Given this list of marker genes NEURL4, PKHD1, MDM2, RITA1, TGIF2, DYNLRB1 (dynein light chain roadblock-type 1), MAP4, FANK1, CDK1, MAPK15, CEP78, DCDC2B, MASTL (microtubule associated serine/threonine kinase like), CEP85, PKD2, NAA40 (NCBI Gene Id 79829), CEP57L1, BUD31, PRKACA, CAMSAP3, CCDC170, KMT5B, ATP6V1D, LHCGR, STIL, PLK2, ATF4, APC (NCBI Gene Id 324), USP20 (NCBI Gene Id 10868), MFAP1, POGZ, GLG1 (golgi glycoprotein 1), RAD51, LRRCC1, KNCN, AGBL4, ACTR1A, FRY, CEP192, IFT74, RAB8A, IST1, CLTC, MAP10, NPHP4, FLCN, RELB, UVRAG, IFT57, NUBP2, KATNBL1, TEDC2, SPAG8, DCAF12, CAMK2B, XRCC2, DEUP1, UBXN2B, SLAIN2, ODAD3, CCDC102B, SPATC1, USP33, KMT2E, LZTS2, HSPA1A, JTB, HMBOX1, WDR11, DYSF, ITSN2, DCTN5, ADCY9, B9D2, CNTRL, CDK5RAP2, TUBE1 (tubulin epsilon 1), SLMAP, TRAF5 (NCBI Gene Id 7188), BRSK1, TM9SF2, FLOT1, GSK3B, FAM110B, SFI1, UNC5CL, TPGS2, TNKS, PIK3R5, KIF7, CCDC112, RAB34, CFAP157, NDN, BBS7, TAP1 (transporter 1, ATP binding cassette subfamily B member), CCNE2, WHRN, KIF3B, CEP152, RAN, MYOF, CRMP1, FANCE, RAB11A, TBC1D30, PRKCQ, CEP162, CDKL2, PSMC4, CLASP1, CEP350, BCCIP, NLRC3, CFAP184, FFAR4, LATS1, CTNNBL1, HAUS2, LRWD1, H2AX, TTC23L, CCP110, CSAG1, PARP3, CEP104, UBXN6, PAK1, MAP7D1, BUB1B, SPMIP4 (sperm microtubule inner protein 4), FBXL7, TUBGCP2, RAD18, TSSK2, TUBG2, FNIP2, RAC1, CD2AP, TSGA10, DYRK3, MTUS1, DYNLRB2, INTU, DCLRE1B, KIAA0753 (NCBI Gene Id 9851), CALML3, PLEKHG6, TTC39A, RAB11FIP4, SNAP29, CEP164, CCDC8, PPP4R2, PDZD7, NCKAP5L, CCNF, HAUS6, RAB6C, MISP, GLI1, CC2D1A, ATM, CETN1, SLC18A2, SMAD3, RLBP1, CADPS2, EPB41L3, CREB1, CEP120, CEP63, CCDC68, ANKS1B, POLA2, ROCK1, CLASP2, BLOC1S2, LRRC45, ODF2, STOX1, FCMR, PDZD2, CCT5, CFAP126, PTPN20, PRKAR2A, PSEN1, RPGRIP1L, TAPT1, MLF1 (NCBI Gene Id 4291), CDC27, CYLD, AGBL2, CFAP100, ASPM, NEK1, RPP25, DCDC2, FRMD8, TEK, HSPA1B, PRKAA2, TTLL6, NPM1, CCNB1, APOBR, BNIP2, ZBED1, SMAD4 (SMAD family member 4), DZANK1, LCK, TULP3, SSNA1, POC5, SASS6, DENND1C, PPP4R3A, MPP1, JADE1 (NCBI Gene Id 79960), ZBED6, NIT2, CLIC4, PRKAA1, PTPN23, PLA2G3, CPLANE2 (ciliogenesis and planar polarity effector complex subunit 2), TOPBP1, ARHGEF10, CKAP2L, TTLL9, KAT2A, DYNC1LI2, PRKAR1A, C2CD3, MICALL1, CFAP206, KLHL4, IFT20, BBS1, ACLY, TRIM32, ORC2, BICDL1, RP2, GAS2L2, CEP72, ZNF330, DZIP1L, IFT43, CAPRIN2, NDE1, MAP7D2, RPS7, CENPF, ATF5, PCNT, CEP41, PIK3R4, RGS14, FAM110C, CNTLN, TSKS, ADRB2, WDR62, CEP20, CHODL, ALDOB, FAM161A, ZFYVE26, CHEK1, GLI2, CHD3, MECP2, DIAPH3, RASSF7, AAAS, GRB2, TBATA, SNCG, TTC12, RTRAF, ENTR1, ADH1B, LRIF1, NAA11, CCDC18, PXK, CCDC81, OFD1, WDR35, KIAA1217, POC1A, EFHC1, IFT22, VIM, FTCD, TRAT1, TTC28, HOOK3, DYNC2LI1, SAC3D1, KIFAP3, CCDC14, TCP1, ZMYND10, IFT172, NDRG1 (NCBI Gene Id 7998), EYS, CCDC57, AKT3, KAT2B, PPP4C (NCBI Gene Id 5531), IFT46, HSF1, TTLL12, CEP57, CEP128, BOD1L2, CCDC61, LRRK2, CEP76, HAUS3, DAPK3, KEAP1, MAPRE2, CBY1, RTTN, KIFC3, KIF3A, CDC14A, SLC8A3, NME3, KIF2B, RABL6, PATJ, CCDC22, NEDD1, EVC, CEP290, PDE4DIP, CCDC92, IRAG2 (inositol 1,4,5-triphosphate receptor associated 2), TTLL4, CFAP20, AKT1, SMAD7, GNAI1, MID1, TRIP4 (thyroid hormone receptor interactor 4), CFAP298, ARMC9, HNMT, SGO1, SDCCAG8, GEN1, STK3, NSFL1C, EEF1AKMT3, DIS3L, CCT4, CHRM2, NINL, BRCA2, VPS4B, MAD1L1, ANKRD26, ARHGEF7, CCNO, TBC1D31, TTLL5, MZT1, MYO18A, VCP, MME, SAXO1, CDK2, DDHD2, TP53, TRIM43, USO1, AGTPBP1, HORMAD2, PIN1, TSG101, SKI, SNTB2, CHMP1A, RIC8B, UBN1, PPP4R3B, ECPAS, CIB1, ARFGEF2, MNS1, NCAPD2, RBM39, MARK4, AKAP11, NDC80, HEPACAM2, E2F1, RAB6A, STK11, MCRS1, KATNAL2, ALS2, NUMA1, PCGF5, MARCHF7, CCNE1, CEP89, DCTN6, RPGR, AUNIP, SLC16A1, KIF5B, SPAST (NCBI Gene Id 6683, spastin), TRIM69 (tripartite motif containing 69), CDC42, RAB11FIP5 (RAB11 family interacting protein 5), CHD4, PODXL, CCDC146, CCDC77, STEEP1, RNF19A, WRAP73, NIN, RAB3IP, EZR, NCBP2, CIBAR1, KATNB1, MICAL1, EML4, IL4R, SKA1, MCPH1, RRP7A, DDX11, CEP131, PSEN2, CALM3, FIGN, FAM234B, CROCC, PRKD3, DYNLT4, HAP1, ATXN10, SCYL1, IL1RN, CLIP1, MKS1, CENPJ, PAX2, USP9X, TAF1D, DLG5, CCSAP, CTSC, MPHOSPH9, DYNC1H1, CDK5RAP3, EFHC2, TSEN2, OLA1 (Obg like ATPase 1), WRN (WRN RecQ like helicase), CDC25B, IQCB1, KIF11, CCDC66, CCDC28B (NCBI Gene Id 79140), FBXW11, NEIL1, TEKT2, SMO, TTBK2, SIRT2, KIF18A, RUVBL1, DNAI1, KATNIP, CDKL5, ARL2BP, YPEL5, CEP95, AURKC, PBOV1, WASHC1, ARL3, CEP126, USH1G, HNRNPU, BOD1, FBXW8, USP50, ACAA2, PPP2R5A, CSNK1A1, DYRK1A, CDC45 (cell division cycle 45), AJUBA, TTLL1, TRAPPC14, TTLL11 (NCBI Gene Id 401550), SPPL2B, RRM1, TCEA2, HOOK2, PSMA1, MAK, ARHGAP35, CUL7, TXNDC9, AXDND1, CCNB2, CEP19, KIF20B, MAPK1, FAM110A, WDR90, CCT8, PJA2, ANKRD45, TBC1D7, PRKACB (NCBI Gene Id 5567), IQSEC1, MAPK3, MPLKIP, PRKCZ, FBF1, TMEM67, PPP4R4, EYA3, DYNLL2, ATP6V0D1, CCDC116, MLLT11, SPACA9, CROCC2, VPS37A, PDCD6IP, ADH1A, S100B, CCDC13, IFT52, SKA3, OCRL, MAMLD1, UBR4, BAG3, PLK1, DPF2, KIF2A, CCND3, TENT5C, NUDT21, RABEP2, EXOC4, ZFYVE19 (zinc finger FYVE-type containing 19), CCDC78, DRD4, GPR174, DHX9, PTK2, PPP1R35, RPAP3, TBCCD1, ZNF322, DYNLT2B (dynein light chain Tctex-type 2B), EMD, NEK7, ABCC3, FAM184A, CCHCR1, POC1B, UTRN, SPOUT1, HTT, ARL13B, NFS1 (NFS1 cysteine desulfurase), TCHP (trichoplein keratin filament binding), CEP170, RILPL2, DBH, LRRC49, DIAPH1, MAP3K11, SCLT1 (sodium channel and clathrin linker 1), RGCC, BRSK2, BCL2L1, RABL2B, CCNJL, KIF13A, KIF17, DYNC2I2, TBCD, YTHDF2, CCDC65, PAFAH1B1, STX1B, CFAP410, IVL, PSMB4, CETN3, NUBP1, CIP2A, CCNJ, ILRUN, NUP85, KIF15, SNX10, WASH3P, ECT2, ATP2B4, CDH23, DAW1, SPATA7, MAP1S, AXIN2, CENATAC, NR3C1, CCDC88C, BIRC5, PRKAR2B, MAPKAPK2, AHI1, CEP295NL, PSKH1, CKAP5, TTLL13, RAB11FIP3, PSMB5 (NCBI Gene Id 5693), BICD1, GNAI2, CCND1, CFAP263, STING1, ACTR1B, CFAP70, CCDC62, CEP135 (centrosomal protein 135), SPECC1L (NCBI Gene Id 8221), C2CD5, RASSF1, HARBI1, NFE2L2 (NCBI Gene Id 4780), TNKS2, ABRAXAS2, CRACR2A, IFT88, CENPU, LUZP1, KIAA0586, TTC19, CCNA2, TTC8, BBS4, DYNC1LI1, TPPP, NEK2, CLIC5, CAMSAP2 (calmodulin regulated spectrin associated protein family member 2), SMG6, CEP112, PCM1, HDAC6, ADH1C, SFR1, CTAG2, AURKB, SEMA4D, CNTROB, PCNA, LIMK2 (NCBI Gene Id 3985), MVB12A, CCND2, CDKN1B, TUBGCP5, DCTN1, KLHL12, CDC42BPG, RAP1GAP2, PLK5, SEPTIN1, MIB1, DDX3X, TMEM201, AKNA, CIBAR2, TTLL2, USH2A, GPSM2, IFT27, ROCK2 (Rho associated coiled-coil containing protein kinase 2), CCDC124, PLAG1, PQBP1, TRAF3IP1, CAPG, NLRC5, MZT2A, HAUS1, ENKD1, IFT80, SMAD6, TOP2A, CEP83, KNSTRN, ALMS1, SPATC1L, DCDC2C, PPP1CC, TUBG1, SLF1, B9D1, NDEL1, PPP1R12A, TTLL7, MMS19, BBS2, CDK10, CCDC50, SPAG9 (NCBI Gene Id 9043), ITGB1BP1, KIF23, HSPA6, TUBD1, SPAG5, CILK1, CLUAP1, CEP44, NEK9, UPF3B, CUL3, HK2, DLGAP5, TP73, CTNND1 (catenin delta 1), MAPRE1, KIZ (kizuna centrosomal protein), CTNNB1, DCTN4, DCTN2, HAUS8, TOGARAM1, CEP68, TACC1, CALM1, DCAF13, RAPGEF6, CSTPP1, IFT56, RAB23, CIMIP2A, CCDC187, GAS8, BIRC7, KHDC3L, VPS4A, NR0B1, AURKA, GPRC5C, KLHL22, ALPK1, CALM2, SSX2IP, NEDD9, PARD6A, BCL3, RABGAP1, GUCA1B, TUBGCP6, CCDC88B, SORBS1, DYNC2I1, EVI5 (NCBI Gene Id 7813), CETN2, SPICE1, ODF1, ARL2, CEP70, CFAP53, DNAAF2, CSPP1, WDR13, CYTH4, SAXO4, USP2, DTX4, CKAP2, NUP62, CFAP90, LCA5, SLC1A4, HOXB4, GPAA1, ZNF12, FEZ1, PHF1, TOPORS, NLRP3, ABCA2, IPMK, RILP, CDC16, EPS8L2, CFAP58, MAP2K1, DYNLL1 (dynein light chain LC8-type 1), CEP85L, KIFC1, AGBL3, BBS9, MDH1, SLC1A5, TMUB1, DISC1, PSME3, TRIOBP, CEP43, ATF3, HERC2, KRT18, EXOC7, CAPN7 (calpain 7), C10orf90, SPDL1, RUVBL2, FBXL13, HMMR, PCLAF, LRP1, RRAGD, CEP250, MKKS, MAGI2, BICD2, ESPL1, RANBP1, PLK4, EGFR, POLR3H, CCDC120, GABARAPL1, ILK, CCDC15, TESK1, TACC2, NEK4, HYLS1, CTDP1, CCDC42, HRAS, ERCC6L2, UXT, PPP2R3C, IFT122, BBS5, BRAF, HAUS4, G6PD, IFT25, PPP1R42, PDIA6, CCDC88A, MAPRE3, RAPSN, PDE4B, DAAM1, PRPF6, STARD9, TEDC1, ANKRD7, BRCA1, RBBP6, CSNK1D, TUBGCP3, AK5, RAB6D, TSC1, NUDCD2, ACTR8, FZD6, RASSF10, TMEM63A, AKAP9, KATNA1, DZIP1, HAUS5, FSD1, CIMAP3, NEK6, CEP97, CABCOCO1, DCTN3, PIBF1, IFT140, CDK6, CFAP96, GIT1, CEP295, APEX1, DNM2, PDE4D, LATS2, HIPK1, ASAP1, LEO1, TPGS1, HAUS7, KIF24, KATNAL1, DYNC1I2, NEK8, YES1, CIR1, C11orf97, MARCKS, GNAI3, PLK3, OBSL1, KIF25, CEP55, SAXO2, CCDC38, BBOF1, MTUS2, TEX9, DCAF1, ZNF365, PLEKHA7, CCNA1, PROSER3, HOOK1, RAD51D, PKN2, BCAS2, CDC20, CD86, CCDC85B, TUBGCP4, BIRC6, RAB6B, CCDC141, PRKCA (protein kinase C alpha), ODF2L, CHRNA3, SKP1, MDM1, RAB28, UNC119 (NCBI Gene Id 9094), AK6, CCDC178, IQCD, KIF2C, RILPL1, SERINC5, NME7, MZT2B, IFT81, PACSIN2, HASPIN, ERC1, GLE1, FLII, TACC3, SPECC1, DTL, PROCR, NUP93, here is a description of the gene set: species: Homo sapiens Human Gene Set: GOCC_MICROTUBULE_ORGANIZING_CENTER An intracellular structure that can catalyze gamma-tubulin-dependent microtubule nucleation and that can anchor microtubules by interacting with their minus ends, plus ends or sides.